The following is a description of a gene set: Mouse Gene Set: GOBP_ORGANOPHOSPHATE_BIOSYNTHETIC_PROCESS The chemical reactions and pathways resulting in the biosynthesis of deoxyribose phosphate, the phosphorylated sugar 2-deoxy-erythro-pentose. species: Mus musculus, and this is the list of marker genes: Atp5mc1, Nme4, Trem2, Impa2, Hdhd5, Pmm1, Dgkg, Gfus (GDP-L-fucose synthase), Npr2, Dgkq, Pank3, Dctd, Shmt2, Ppara, Gnpnat1, Dgkk, Akr1a1, Sdhb, Mdh1, Gfpt2, Uap1, Npr1, Elovl7 (NCBI Gene Id 74559), Uprt, Tafazzin, Gars1, Pik3ca, Acacb, Nppa (NCBI Gene Id 230899), Erbb4, Cln3, Ppip5k1, Pdhb, Dut, Pygl, Ckmt1, Pdha2, Pnpo, Chpt1, Atp5f1c, Pnp2, Pth1r, Pla2g4a, Uap1l1, Fdps, Pi4kb (NCBI Gene Id 99948), Nudt2, Ndufc2, Shmt1, Cmas, Ndufb10, Dpm2, Ndufs2, Adcy3, Idi1, Gmppb, Ajuba, Capn2, Dgkb, Ptdss2, Pcyt1a, mt-Nd2, Adcy5, Ndufs8, Pi4k2b, Pcyt1b, Impdh2, Pik3cb, Gmds, Ippk, Ldhc, Agpat5, Mpi, Ptafr, Impdh2-ps, Pigh, Ndufa9, Ak1, Osbp, Pfas, Nme6, Atg5lrt, Upp1, Acsl5, Letmd1, Qprt, Atp6v1a, Prpsap2, Dnajc30, Gpd1, Tk2, Ndufb11, Gpam, Nmrk1 (nicotinamide riboside kinase 1), Ndufs5, Slc25a42, Umps, Tpi1, Amdhd2 (NCBI Gene Id 245847), Gucy2d, Rab38, Gucy2f, Nme7, Kynu, Inpp1, Becn1, Pank1, Pik3cd, Nppb, Ptpmt1, Gmps, Prps2, Plcg2, Alox15, Ndufa2, Lcat, Vac14, Flvcr1, Slc35a1, Pmm2, Mboat2, Pigt, Mthfd2l (methylenetetrahydrofolate dehydrogenase (NADP+ dependent) 2-like), Ndufv2, Nppc, Atp5mf, Pnp, Ido1, Ppcdc, Dpm3, Gucy2g, Ak5, Cwh43, Chka, Aspdh, Adcy4, Pik3c2g, Sphk2, Pck1, Gnpda2, Ndufb7, Pigp, Etnk2, Ndufa5, Dgkh, Papss2, Gne, Dcxr, Pgk1, Dgke, Eno1b, Ndufa6, Dip2a, Pdhx, Gucy1b1, Nme2, Serac1, Vcp, Dhdds, Pip4k2c, Dolk, Prkn, Fgf7, Atp5mc3, Ppip5k2, Pou1f1, Pgam1, Nadk, Prkg1, Idi2, Avpr1b, Dmac2l, Abhd5, Cdipt, Pdk2, Acsl4, Gpaa1, Ndufa13, Acss1, Ttc7, Dgkz, Tgfb1, Ormdl3, mt-Atp8, Tmem150a, Lclat1, Apoa1, Abca8a, Pigo, Hprt1, Pdk3, Pyurf, Cmpk2, Atm, Ugdh, Elovl4, Gk2 (NCBI Gene Id 14626), Htr2a, Hexb, Pigx, Rfk, Slc2a1, Pld1, Slc25a51, Plcg1, Pigf, Sptlc2 (NCBI Gene Id 20773), Dck, Ak6, Ndufa12, Mmaa, Ctps1, Tk1, Ndufb3, Nadsyn1, Mboat1, Agpat2, Sdhd (NCBI Gene Id 97524), Ak3, Adcy6, Pik3c2a, Pank4, Rd3, Slc25a10, Atp6-ps, Adcy7, Ak7, Mapk1, Plcd1, Itpkb, mt-Nd5, Inppl1, Abca8b, Ak4, Atp5po, Fuom, mt-Nd6, Ppard, Fabp5, Pik3c3, Atpsckmt, Crls1, Slc25a12, Inpp5e, mt-Nd4, Pgap4, Ndufs6, Nmnat2, Xylb, Acaca, Gmpr, Samd8, Fabp3, Atg14, Gper1, Ip6k3, Dgkd, Ipmk, Ndufab1, Abhd8, Pigg (phosphatidylinositol glycan anchor biosynthesis, class G), Atp5f1d, Ppcs, Uckl1, Ndufa7, Ndufs4, Guca1b, Kmo, Mdh2, Fig4, Hycc2, Nadk2, Mas1, Bscl2, Ndufb4, Nme5, Mboat7, Gmppa, Slc30a5, Pip5k1c, Cda, Rrm2b, Gucy1a1, Pgm3, Dguok, Adcyap1r1, Pld2, Gucy2e, Tmsb4x, Plaat3, Ckmt2, Rrm1 (ribonucleotide reductase M1), Parp1 (NCBI Gene Id 98479), Dld, Gpat3, Gk, Pign, Ampd3, Gk5, Lpcat1, Nr1h4, Ldhd, Pigv, Pgs1, Adss2, Atp5pd, Adcy1, Map2k1, Haao, Ndufv3, Pla2g6, Gmpr2, Cd244a, Cryl1, Uxs1, Pdha1, Rrm2, Pmvk, Ak9, Pemt, Ptdss1, Lhcgr, Uck1, Adk, Ada, Adcy8 (adenylate cyclase 8), Myh9, Antkmt, Cds2, Pank2, Pik3r1, Ip6k2, Gpat4, Htr2b, Dlat, Nos3, mt-Nd4l, Hk1, Oasl2, Gapdh, Cept1, Slc25a13, Lpcat2, Uqcc3, Kars1, Slc19a3, Acss2, Stoml2, Ggps1, Elovl6, Inpp4a, Adcy2, Pip4k2a, Piga, Slc52a3, Lpcat4, Vapa, Nmnat1, Efr3b, Lpcat3, Fcsk, Ppat, Aprt, Pcx, Nmnat3, Acat1, Slc25a16, Pid1, Guca1a (NCBI Gene Id 14913), Ndufa8, Pi4ka (NCBI Gene Id 224020), Dgka, Pigs, Ak8, Acsl1, Bpnt1, Tpk1, Sh3glb1, Pik3cg, Ndufb1, Plscr3, Bckdk, Gpat2, Eno1, Abhd4, Prpsap1, Mocs2, mt-Atp6, Ndufb5, Atp5me, Ndufs7, Adcy9, Mocs3, Etnk1, Mvk, Serinc4, Chkb, Fitm2, Dhrs7b (dehydrogenase/reductase 7B), Atic, Pigw, Tkt, Pip4k2b, Ndufa10 (NADH:ubiquinone oxidoreductase subunit A10), Atp5mg, Ido2, mt-Nd3, Cad, Scp2, Idh2, Ckm, Gphn, Ugp2, Guk1, Prps1, Entpd8, Tyms, Dhfr (dihydrofolate reductase), Impdh1, Myc, Pisd, Serinc1, Afmid, Ndufa11, Apoa2, Inpp4b, Pth2, Mocos, Flad1, Acot7, Nanp, Pdk4, Ndufc1, Pi4k2a, Pth, Mpc2, Gucy2c (guanylate cyclase 2c), Naprt, Mpc1, Idh1, Dcakd, Adsl, Ckb, Fpgt, Gykl1, Gart, Cds1, Slc35c1, Thtpa, Sdha, Isyna1, Cmpk1, Pip5k1a, Atp5f1a, Pigu, Pcyt2, Nme3, Coasy, Pigl, Uvrag, Pigb, Acsl3, Agpat3, Elovl3, Fam3a, P2ry6, Pdgfb, Mocs1, Slc4a7, Pla2g5, Pdk1, Dgki, P2ry1, Pigm, Impa1, Slc27a1, Pip5k1b, Nus1, Pigc, Ndufv1 (NCBI Gene Id 225885), Dtymk, Pdgfa, Ip6k1, Abca2, Snca, Stat3, Adss1, Plek, Hmgcs2, Ampd1, Itpka, Nans, Ttc7b, Ntsr1, Ctps2, Bpnt2, Htr2c, Sdhc, Pdxk, Mppe1, Pnpla3, Entpd1, Pgap3, Cox11, Agpat1 (1-acylglycerol-3-phosphate O-acyltransferase 1), Ndufb2, Nme1, Aldoa, Adora2b, Lpcat2b, Nfs1, mt-Nd1, G6pd2, Pik3c2b, Hycc1, Mmut, Mthfd1, Chp1, Atp5if1, Ampd2, Sh3yl1, G6pdx, Ndufb8, Paics, Nmrk2, Elovl5, Fitm1, Lpgat1, Gcdh, Selenoi, Atp5pf, Dpm1, Pla2g4c, Lipa, Oas1a, Tmem38b, Ndufs3, Ak2, Bcl2l1, Hmgcs1, Nampt, Plscr1, Pgap1, Pigz, Agpat4, Ndufa1, Pik3r4 (phosphoinositide-3-kinase regulatory subunit 4), Mlycd, Smg1, Pigyl, Pgap2, Atp5pb, Mvd, Sgms1, Ndufb6, Prps1l1, Slc52a2, Slc25a19, Hnf1a, Dhodh, Acsl6, Sord, Ndufa3, Itpkc, Cps1, Adgrf5, Prps1l3, Far1, Atp5mc2, Papss1, Ormdl1, Atp5f1b, Gnpda1, Tamm41, Pigq, Pigk, Upp2, Ndufs1, Elovl1, Sptlc1 (serine palmitoyltransferase, long chain base subunit 1), Ptprq, Pip5kl1, Ndufb9, Adcy10, Slc19a2, Serinc5, Il4, Tbpl1, Vdac1, Uck2, Gfpt1, Atp5f1e, Sgms2, Acly